Given this list of marker genes DNA2, IGF1, BRCC3, TRIO, ZFHX4, here is a description of the gene set: Human Gene Set: HP_CONGENITAL_PTOSIS studied in species Homo sapiens Congenital ptosis